The following is a description of a gene set: Nuclear RNA decay Mouse Gene Set: REACTOME_NUCLEAR_RNA_DECAY species: Mus musculus, and this is the list of marker genes: Rbm26, Exosc3, Ncbp1, Exosc2, Exosc10 (NCBI Gene Id 50912), Rbm7, Mtrex, Wdr82, C1d, Exosc6, Zc3h3, Pabpn1, Exosc4, Ythdc2, Exosc5, Exosc8, Dis3, Zc3h18, Exosc7, Ythdc1, Ncbp2, Mphosph6, Rbm27, Exosc9, Papolg, Exosc1, Zc3h4, Zcchc8, Zfc3h1, Srrt